The following is a description of a gene set: species: Homo sapiens Human Gene Set: GSE1460_INTRATHYMIC_T_PROGENITOR_VS_DP_THYMOCYTE_DN from publication Lee MS, Hanspers K, Barker CS, Korn AP, McCune JM (PMID 15210650) Subpopulations of human fetal thymocyte and circulating naïve T cells were obtained through FACS sorting, including CD3-CD4+CD8- intrathymic T progenitor cells (ITTP), CD3intCD4+CD8+ \double positive\ thymocytes (DP), CD3highCD4+CD8- \single positive\ thymocytes (SP4), CD3+CD4+CD8-CD45RA+CD62L+ naive T cells from cord blood (CB4+), and CD3+CD4+CD8-CD45RA+CD62L+ naive T cells from adult blood (AB4+). Genes down-regulated in comparison of intrathymic T progenitor cells (ITTP) versus CD4 CD8 thymocytes., and this is the list of marker genes: CD52, ATG16L1, PSG11, CRELD2, SIRPA, ASTN2, RER1, CENPA, STAG3, PHLDA2, IL23A, ROCK1, DENND2D, PLCH2, CBFA2T3, APBB1, LPGAT1, AGBL2, KDM5A, GPR19, PPP1R13L, OPRD1, LY9, WDR19, ARHGEF7, PLCH1, IL21R, EGR1, FOXP3, SLC35E3, STX11, SIT1, COMMD4, ARPIN, CD1D, SLC7A6, TONSL, MAP6D1, TESMIN (NCBI Gene Id 9633), PSPC1, GPATCH2, PIM2, HIVEP2, APH1B, MYH9, AKAP7, PPP2R5B, SKAP1, SLC9A8, SPRY2, ITPKB, RPRM, SLC25A44, SLAMF1, CARD8, DUSP2, TRAF3IP3, FBXL12, VASP, VOPP1, RIPK4, SOX17, LCP2, CABIN1, CLK4, CD38 (NCBI Gene Id 952), FERRY3 (NCBI Gene Id 57200), MBTPS2, CTDSP2, TTK, PDE4D, KDM4B, SGK1, GABARAPL1, CDKN2A-AS1, FAT1, SH2D3A, TAPBPL, RHOBTB2, COL6A3, ST3GAL5, KCNC4, MPPE1, TRDV2, MVB12B, MAST4, SH2D2A, ARSL, RAPGEF6, H2BC4, BMAL1 (basic helix-loop-helix ARNT like 1), TUBA4A, TSC22D3, EEIG1, DGKA, ACSBG1, CWC25, PGS1, CELA2B, CEP350, ZMIZ2, PLEKHM1, CCR9, SLC6A7, TRBC1, LYST, ST6GAL1, CHRNA3, TENM1, IL17B, GSPT2, OR7E47P, ING1, ATP9B, RHEB, VEGFC, H4C8, IER2, TLE4, EVI2A, CD8A, XCL1, CARMIL1, FBLN5, ABHD8, IL32, CIB2 (NCBI Gene Id 404086), RGR, ITIH4, XPO4, GALNT12 (NCBI Gene Id 79695), CRTAM, RAD52, SIX5, KBTBD11, ADRA2B, SRD5A2, TRPM3, POR, RGCC, GPR153, CAPN3, NR1H2, POU3F4, ENC1, FCMR, ATG4A, APC, LBH, SLC12A4, KAT2B, PCMTD2, IFT88, CA8, TGFBR2, BBIP1, TNFSF14, ASL, TIAM1, EGLN1, CXCL3, TNFAIP3, LRFN3, FOXO4 (forkhead box O4), EDEM1, PLCL1, PPP1R15A, DNMBP, PIP4K2C (phosphatidylinositol-5-phosphate 4-kinase type 2 gamma), ERP44, ISG20, SYNE1, CGGBP1 (NCBI Gene Id 8545), NOS3, WWC1, FRY, MEAK7 (MTOR associated protein, eak-7 homolog), EGR3, CD244, MITF, EXOC2, HDAC5, FNDC3B, CCNI, ARPP21, CCN2, BCL6, MAPK13, NMB, RIC8B, FAM53C (family with sequence similarity 53 member C), TBC1D19, TRAC, FRZB, BAZ2A, LBP, ELK3